Given this list of marker genes KDM2B, CYTH3, ARHGAP21, DOCK6, MOB1B, TMEM63B, ZBTB18, ARK2N, TEAD1, CNOT4, WDR20, PRR5L, B4GALT2, ELAPOR2, E2F7, ARFGEF1, SZRD1, ITGA11, STRADB, SLC2A1, TNPO3, PNPLA6, UBE2D1, PRKAG2, B4GALT5, ZNF784, ITGA5, NR2C2AP, ROBO2, UBE2W, BTBD10, PHF3, BRPF1, ADAMTS18, ITSN2, MLEC, KLF4, PCDH10, OTX1, NHS, PHACTR2, ATG14, PICALM, NRP1, LSM14A, PLEKHH1, RORB, SSR1, LIMD2, NAA15, MAX, AP4E1, ERLIN1, GDF6, WNT10B, ACVR1, HOXC8, XPO4, NSD2 (NCBI Gene Id 7468), TMEM9B, OSBPL11 (NCBI Gene Id 95889), FOSB, TBL1XR1, ARHGEF17, PBXIP1, DYRK1B, SLF2, PDIA3, CSF1, YWHAB, TNRC6B, ARL6IP1, RUNX2, CAMK2A, DICER1, ATP2A2, LBR, ZCCHC2 (zinc finger CCHC-type containing 2), HMGB3, ZFYVE26, CLOCK, TGFA (NCBI Gene Id 7039), CPEB4, MDFIC, ARHGEF12, USP33, STX3, TAF4, MACIR, ARFIP1, SYNJ1, BMP1, RNF217, ARPP19, HAS3, CDK19, SKIDA1, SLC25A44, PDK4, KLHL18, POU4F2, DEDD, NDST1, ARGLU1, ATP7A, MEOX2, GMFB, PPP6R1, SCAF11, EPS15, SOX11, ZNRF1 (zinc and ring finger 1), GPM6A, MOSPD1, RSBN1L, GPCPD1, ARK2C, RLIM, ATXN1, ESR1, MGAT4A, PLAA, ETV5, S1PR1 (sphingosine-1-phosphate receptor 1), SRSF11, PATL1, SPRY3, INO80, C6orf62, SNX27, MAF, MPPED2, SGMS1, USP6, FBXL19, TRPM2, RXRA, CYB5R4 (cytochrome b5 reductase 4), ROBO1, MTMR14, ANK2, OTUD4, HSP90B1, DNER, C1GALT1, PIK3R3, CUL5, EFNB2, RAB34, NRARP, PPP1R12A, KIAA1217, CAND1, NPTN, DNMT1, PPARGC1A, ZFPM2, COL2A1, CCDC71, TSPOAP1, FAM13B, RBM24, ARL8B, RMND5A, TMEM266, SIX4, BCL7A, SULF1, SMS, RNF44, MDGA2, MAF1 (NCBI Gene Id 84232), NME7, AGO4, AGO1, DPP3, RXFP2, KLC2, POU3F2, DYNLL2, MNT, TMED7, CNTN4, ITPK1, DMXL1, NEURL4, FYB2, WNT1, ARRDC3, ABCB7, YPEL3, USP32, GPRC5B, FBXO33, CPD, ELF5, CANX, ESRRG, CFL2 (cofilin 2), CDC14A, MTMR12, EP300, PTPRM, UBR1, MAFB, FAM234A, CDK5R1, MLLT6, SNN, FMR1, LRRC55, CHRD, GLRX5, TXNIP, MMP19, CNOT6, MED12L, ZBED4, KANSL1, RELCH, MMD, CABP7, AKAP1, LIN28A, USP32P2, ABTB3, CHD7, PRICKLE2, LZTS3, PRKAA1, GADD45A, RAB35, PWWP3B, SIK1, E2F3, ST8SIA3 (ST8 alpha-N-acetyl-neuraminide alpha-2,8-sialyltransferase 3), BAZ2A, RALBP1, SEPTIN4, MARCHF2, RPS6KA5, MIER1, STXBP5, MTF1, BCL11A, TMSB10, LMTK2, ANAPC1P2, ZNF217, MLLT10 (MLLT10 histone lysine methyltransferase DOT1L cofactor), RNF38, TOMM70, ERBB3, BTBD3 (BTB domain containing 3), AKAP7, FBN1, SLC25A3, TRPS1, MITF, ERRFI1, KMT2A, AGFG1, KIAA0232, MAP3K9, UCP3, SAMTOR, SLC7A11, TRAK2, NPEPL1, STARD13, SKP1, BACH2, TENT2, QKI, SYT1, FBXO11, GAP43, RICTOR (RPTOR independent companion of MTOR complex 2), BTAF1, INHBB, DDX6, HECW2, PHAF1, GPATCH8, TNRC6A, TGIF2, SNPH, USP48, LDLR, NPTX1, MARCHF3, LTBP1, PPP1CB, EPN2, JPH3, ABCA1, CHD9, RGMA, NCOA1, NLK, ADCY2, BEST1, SLC24A3, VCF1, ELMO1, SIRT7, NOG, here is a description of the gene set: Human Gene Set: TGCACTG_MIR148A_MIR152_MIR148B studied in species Homo sapiens Genes having at least one occurence of the motif TGCACTG in their 3' untranslated region. The motif represents putative target (that is, seed match) of human mature miRNAs hsa-miR-148a, hsa-miR-152 and hsa-miR-148b (v7.1 miRBase).